The following is a description of a gene set: Mouse Gene Set: LIM_MAMMARY_STEM_CELL_UP Genes consistently up-regulated in mammary stem cells both in mouse and human species. studied in species Mus musculus INTRODUCTION: Molecular characterization of the normal epithelial cell types that reside in the mammary gland is an important step toward understanding pathways that regulate self-renewal, lineage commitment, and differentiation along the hierarchy. Here we determined the gene expression signatures of four distinct subpopulations isolated from the mouse mammary gland. The epithelial cell signatures were used to interrogate mouse models of mammary tumorigenesis and to compare with their normal human counterpart subsets to identify conserved genes and networks.METHODS: RNA was prepared from freshly sorted mouse mammary cell subpopulations (mammary stem cell (MaSC)-enriched, committed luminal progenitor, mature luminal and stromal cell) and used for gene expression profiling analysis on the Illumina platform. Gene signatures were derived and compared with those previously reported for the analogous normal human mammary cell subpopulations. The mouse and human epithelial subset signatures were then subjected to Ingenuity Pathway Analysis (IPA) to identify conserved pathways.RESULTS: The four mouse mammary cell subpopulations exhibited distinct gene signatures. Comparison of these signatures with the molecular profiles of different mouse models of mammary tumorigenesis revealed that tumors arising in MMTV-Wnt-1 and p53-/- mice were enriched for MaSC-subset genes, whereas the gene profiles of MMTV-Neu and MMTV-PyMT tumors were most concordant with the luminal progenitor cell signature. Comparison of the mouse mammary epithelial cell signatures with their human counterparts revealed substantial conservation of genes, whereas IPA highlighted a number of conserved pathways in the three epithelial subsets.CONCLUSIONS: The conservation of genes and pathways across species further validates the use of the mouse as a model to study mammary gland development and highlights pathways that are likely to govern cell-fate decisions and differentiation. It is noteworthy that many of the conserved genes in the MaSC population have been considered as epithelial-mesenchymal transition (EMT) signature genes. Therefore, the expression of these genes in tumor cells may reflect basal epithelial cell characteristics and not necessarily cells that have undergone an EMT. Comparative analyses of normal mouse epithelial subsets with murine tumor models have implicated distinct cell types in contributing to tumorigenesis in the different models. from publication Lim E, Wu D, Pal B, Bouras T, Asselin-Labat ML, Vaillant F, Yagita H, Lindeman GJ, Smyth GK, Visvader JE (PMID 20346151), and this is the list of marker genes: Rfx2, Oxtr, Prickle1, Ppp1r18, Cnp, Tmem201, Pcbp4, Tmem204, Igfbp4, Tie1, Sema5a, Igfbp3, Rarb, Stac2, Lamb1, Arc, Fgl2, Osr1, Arhgef28, Ephb1, Ttyh2, Egr3, Hs3st3a1, Pdlim4, Cacnb4, Zc3h12b, Slc38a5, Has2, Acta2, Mrgprf, Bves, Gja1, Gem, Cdh13, Csrp2, Rasip1, Timp3, Cd70, Cryab, Mia, Mbnl1, Enc1, Aqp9, Abtb3, Qki, Gpc3, Phldb1, Cygb, Mmp2, Twist2, Il17rd, Ssh1, Tamalin, Mgarp, Klhl29, Vsir, Adgrl1, Gpr176, Lag3, Cd36, Dmwd, Col16a1, L3hypdh, Spred1, Lgals7, Trim29, Ppp1r3c, Krt75, Adarb1, Ppp1r16b, Col17a1, Stxbp4, Neto2, Plxna2, Sobp (NCBI Gene Id 78400), Tcof1, Pcdh18, Sema3c, Prnp, Bnc1, Nudt11, Col5a2, Dcbld2, Luzp1, Popdc2, Gjc1, Bag3, Irag1, Ark2c (NCBI Gene Id 72870), Ebf3, Fxyd1, Agpat4, Dlk2, Dst, Tsku, P3h2, Serpinf1, Itga9, Ext1, Prrx1, Lamc1, Slc27a3, Pard6g, Amotl1, Col18a1, Serpinh1, Il6, Fez1, Lrp4, Gpr3, Cdh4, Lama1, Egr2, Lamb3, Il6st (NCBI Gene Id 71317), Col14a1, Adgra2, Nudt10, Clip3, Postn, Angptl2, Krt5, Slc4a3, Jam2, Lifr, Zfp423, Sec24d, Bcl2l11, Rcsd1, Cblb (Casitas B-lineage lymphoma b, NCBI Gene Id 208650), Col4a1, Qrich2, Rasl12, Tshz3, Mef2c, She, Lgals1, Gypc, Fermt2, Tmem47, Ccdc3, Kank4, Col7a1, Sh3tc1, Snai2, Arhgef25, Tcf7l1, Calml3, Lrp1, Mxra7, Ngf, Vcan, Cdc42ep2, Lep, Tmem64, Epas1, Scarf2, Slc6a8, Golim4, Nrcam, Jag1, Pcdh19 (NCBI Gene Id 279653), Lmod1, P3h1, Ptgs2, Podn, Rarres2, Asphd2, Msrb3, Tspyl3, Tgfbr3, Actg2, Fas, Kcnip3, Serping1, Nrg1, Gng11, Srgn, Slc25a4, Vim, Slit3, Ski, Dusp6, Pxn, Hgfac, Ppp1r14a, Fhod3, Medag, Nptx2, Peg3, Nsg1, Lca5, Tpst1, Ptprt, Ndn, Bmal1 (basic helix-loop-helix ARNT like 1), Arhgap25, Bcor, Plpp1, Sdk2, Myc, Osbpl6, Mme, Card10, Sntb2, Tcf4, Erf (NCBI Gene Id 13875), Ntf3, Cav1, Pdpn, Pgf, Tgfb1i1, Evc, Clxn, Prickle2, Rusc2, Bmp7, Gsn, Gpr87, Eva1a, Bmp1, Col4a2, Fabp5, Lcat, Wipf1, Eepd1, Meg3, Nlgn2, Eogt, Siah2, Acer2, Rnd3, Plekha4, Hdac4, Slc27a6, Arsi, Myl9, Ntrk2, Ssbp2, Ccdc85b, Schip1, Cnn1, Lrrn1, Col12a1, Dpysl3, Sh2d5, Eid3, Sorcs1, Malt1, Fzd8, Tmem255b, Srpx, Pakap, Zfp219, Inka1, Msx1 (NCBI Gene Id 269644), Mest, Flnc, Maob, Itgb4, Vgll3, Aldh1l2, Chst7, Mtcl2, Pcdhgc3, Mylk, Edaradd, Scn4b, Cavin2, Tox, Epdr1, Slc1a3, Col5a1, Lbh, 1600014C10Rik, Abi3bp, Dock10, Cdkn1a, Flrt2, Mical2 (microtubule associated monooxygenase, calponin and LIM domain containing 2), Pamr1, Pdgfa (NCBI Gene Id 18590), Ctnnal1, Tshz2, Thbs1, Hacd1, Vsnl1, Dusp7, Nrp1, Itga6, Crispld1, Myh11, Il17b, Tm7sf3, Psd2, Nbl1 (NCBI Gene Id 17965), Tmem121, Tenm3, Tacc1, Csdc2, Sorbs1, Ism1, Thy1, Tpm2, Pla2g7, Cnrip1, Fjx1, Klhl21, Cpxm1, Nxn, Slc2a3, Ccnd2, Mamdc2, Itgb1, Pros1, Mpdz, Efnb1, Rab34, Plch2, Vit, Aebp1, Nectin3, Lims2, Itga1, Dcun1d3, Slit2, Enpp2, Lhfpl6, Trp63, Acvr2a, Stac, Pou3f1, Col9a2, Unc45a, Ngfr, Calu, Wtip, Adamts1, Tns4, Synm, Clmp, Htra1, Atp2a2, Tro (NCBI Gene Id 64836), Lima1, Lrrc8c, Pxdc1, Upp1, Sbspon, Bach1, Ankrd1, Akt3, Rbpms, C1qtnf4, Pdlim7, Lama3, Crlf1, Dchs1, Pcdh7, Svep1, Bcar1, Il24, Reln (reelin), Smim13, Ahi1, Ucn2, Sgcb, Trpc1, Cdh3, Fam184a, Rhoj, Prdm1, Cpne8, Lrch2 (NCBI Gene Id 278230), Trim9, Slco3a1, Pls3, Ltbp4, Tagln, Smtn, Rflnb, Krt16, Stard8, Ets1, Apoe, Tns1, Mtss1, Sgip1, Tbx2, Gnb4, Reck, Krt14, Foxp1, Ecrg4, Fbln7, Elovl4, Tmem178, Mcam, Chst3, Col23a1, Prx, Nt5e, Myocd, Rcn3, C1qtnf12, Nrp2, Tes, Cald1, Sulf1, Snca, Gpsm1, Antxr1, Itm2a, Id4, Pknox2, Matn2, Map3k7cl, Cadm1, Slc1a5, Phlda3, Egfr, Hspb2, Sox11, Dipk2a, Simc1, Kcnma1, Igfbp2, Arhgap20, Pkp1, Hras, Kcnmb1, Yaf2, Mfng, Cspg4, Poglut2, Syde1, Aopep, Icam1, Hspg2 (NCBI Gene Id 15530), Elk3, Ppp2r2b, Klhl42, Tubb6 (NCBI Gene Id 67951), Pkd1 (NCBI Gene Id 224620), Irx4, Heg1, Dzip1l, Large2, Rapgef1, Il1b, Lgr6, Elp5, Pcolce, Ednrb, Plpp3, Scml2, Adamts2, Cxcl14, Dkk3, Fbxo30, Jam3, Nnmt, Tinagl1, Ccn2, Arhgap24, Fmod, Fhl1, Fam216a, Wif1, Slc12a4, Axl, Gnai1, Thsd1, Armh4, Fst, Dll1, Igfbp6, Sphk1, Ptpre, Tspyl2, Fgfrl1